The following is a description of a gene set: part of: Cytochrome c-mediated apoptotic response Reactome Pathway: Activation of caspases through apoptosome-mediated cleavage electronically inferred by orthology from the curated human pathway species: Mus musculus This event has been computationally inferred from an event that has been demonstrated in another species.<p>The inference is based on the homology mapping from PANTHER. Briefly, reactions for which all involved PhysicalEntities (in input, output and catalyst) have a mapped orthologue/paralogue (for complexes at least 75% of components must have a mapping) are inferred to the other species., and this is the list of marker genes: Casp3, Cycs, Casp9, Casp7